Given this list of marker genes DNA2, SEMA3F, MCU, NWD2, STK40, RGPD6, SHISA6, USP32, CDYL2, MIB1, PRR13 (NCBI Gene Id 54458), LRRC70, CEP170 (NCBI Gene Id 9859), OSM, PCDH19, APOBEC3H, TMEM35B, PRH2, RGPD8, SLC24A3, AUNIP, HYAL4, G6PC1, RGPD5, CELF4, GMFB, SLC24A4, MECP2, NOVA2, CHD4, ZPBP2, GSPT1 (NCBI Gene Id 2935), CLUL1, FBP1, C2CD5, SPOCK1, CNOT6L, PLEKHS1, JCAD, TAOK1, LCE2C, RIMS3, OXSR1, SON, FRYL, EPM2AIP1, HNRNPH1, SNX16, PPP6C (protein phosphatase 6 catalytic subunit), ARMC7, PRTG (protogenin, NCBI Gene Id 650816), EN2, CORO2B, ABLIM3 (actin binding LIM protein family member 3), PYCR2, RELN, ZKSCAN1, RUNDC3B, FHIP1A, FAM83A, VAMP1, PPP1R16B, COBL, PIM1, TOPORS, KAZN, ZNF333, ATP6V1A, KAT6A, YIPF6, MTCL2, MAL2, ZDHHC9, UBE2Q1, RBIS, NUFIP2, PTGER3, NRM, EPHA7, SLC25A35, MYO6, RAB8A, MEF2D, VAX1 (NCBI Gene Id 196056), SLC9A5, MAX, CD55, FCHSD2, MYO1D, APH1A, KMT2A, PICALM, LGI2, YWHAE, ZNF444, PRRC2B, SORCS1, RTKN2, ARID1A, RNF5, ZBTB7A, TRIM67, CLCN3, SMG5, here is a description of the gene set: from publication Chen Y, Wang X (PMID 31504780) studied in species Homo sapiens Genes predicted to be targets of miRBase v22 microRNA hsa-miR-12118 in miRDB v6.0 with MirTarget v4 prediction scores > 80 (high confidence targets). Human Gene Set: MIR12118